Given this list of marker genes Hdac6, Gpbar1, Mtor, Lims2, Pkhd1, Lims1, Mki67, Cdc25a, Notch2, Nppb, here is a description of the gene set: studied in species Mus musculus The multiplication or reproduction of cholangiocytes, resulting in the expansion of the cholangiocyte population. A cholangiocyte is an epithelial cell that is part of the bile duct. Cholangiocytes contribute to bile secretion via net release of bicarbonate and water. Mouse Gene Set: GOBP_CHOLANGIOCYTE_PROLIFERATION